The following is a description of a gene set: Mouse Gene Set: GOBP_PHOSPHATIDYLINOSITOL_METABOLIC_PROCESS species: Mus musculus The chemical reactions and pathways involving phosphatidylinositol, any glycophospholipid in which a sn-glycerol 3-phosphate residue is esterified to the 1-hydroxyl group of 1D-myo-inositol., and this is the list of marker genes: Pigl, Cwh43, Inpp1, Itpkb, Pgap1, Inpp5d, Synj2, Ip6k1, Pgap3, Pign, Pip4p2, Slc30a5, Ip6k3, Pigc, Gpaa1, Htr2b, Plcb3, Pigf, Plcg2, Pik3cb, Pigq, Uvrag, Cds1, Ttc7b, Inppl1, Mboat7, Plcl1, Pip4p1, Pten (NCBI Gene Id 70161), Pigp, Pi4k2b, Inpp5f, Inpp5j, Plcd1, Pigk, Dpm2, Pip5kl1, Pip5k1b, Pik3cd, Pdgfb, Efr3b, Pgap2, Plce1, Plch2, Mtmr10, Inpp5e, Hycc2, Mtmr11, Pla2g3, Pik3c3, Pi4kb, Tmem150a, Atm, Agpat5, Pip5k1c, Synj1, Pip4k2c, Dgke, Mtmr2, Sacm1l, Becn1, Pik3cg, Inpp5k, Plcb4, Mtmr9, Sh3yl1, Ptprq, Fig4, Mtmr4, Pik3r5, Pik3ca, Mtmr3, Pigx, Pitpnc1 (NCBI Gene Id 77221), Smg1, Pigv, Mtmr12, Plcl2, Lpgat1, Mtmr7, Chrm5, Pik3c2g, Htr2c, Ipmk, Pip4k2b, Plcg1, Pigt, Pik3c2b, Plch1, Dpm1 (NCBI Gene Id 98872), Pyurf, Pigu, Pgap4, Ddhd1, Itpka, Pik3r1, Pigo, Ip6k2, Atg14, Pigh, Pdgfrb, Cdipt, Plcd4, Bpnt1, Pigw, Pip4k2a, Bpnt2, Pigs, Pikfyve, Ptpmt1, Pik3r4, Mppe1, Vac14, Slc27a1 (NCBI Gene Id 26457), Pigb, Pdgfa, Pigyl, Lclat1, Pi4ka, Inpp5a, Inpp5b, Inpp4a (inositol polyphosphate-4-phosphatase, type I), Mtm1, Piga, Pigz, Pi4k2a, Inpp4b, Pigm, Plcb2, Agap2, Galr2, Tnfaip8l3, Itpkc, Pip5k1a (phosphatidylinositol-4-phosphate 5-kinase, type 1 alpha), Htr2a, Dpm3 (NCBI Gene Id 99854), Impa2, Hycc1 (hyccin PI4KA lipid kinase complex subunit 1), Pik3c2a, Mtmr6, Ocrl, Mtmr1, Impa1, Plek, Pigg, Ttc7, Plcb1